Given this list of marker genes PNLIP, GUCY2C, TREH, LIPF, AMY1A, PIR, NPC1L1, CHIT1, PNLIPRP2, GUCA2B, SLC2A2, AMY2A, SLC2A5, GUCA2A, ALPI, AMY1B, CHIA, AMY2B, RSC1A1, MGAM, SLC5A1, CLPS, LCT, PNLIPRP3, AMY1C, SI, PNLIPRP1, CEL, here is a description of the gene set: Digestion and absorption species: Homo sapiens Human Gene Set: REACTOME_DIGESTION_AND_ABSORPTION